The following is a description of a gene set: species: Mus musculus Any process that stimulates, induces or increases the rate of macrophage activation. Mouse Gene Set: GOBP_POSITIVE_REGULATION_OF_MACROPHAGE_ACTIVATION, and this is the list of marker genes: Irgm1, Mmp8, Il4ra, Il10, Kcnn4, Ttbk1, Hspd1, Hamp, Tafa3, Lrrk2, Wnt5a, Jund, Raet1d (retinoic acid early transcript delta), Tlr4, Ctsc, Tlr6, Lgals9, Il33, Kars1, Pla2g4a, Stap1, Cebpa, Il1rl1, Thbs1, Tnip2, Il13 (NCBI Gene Id 16163), Havcr2, Ulbp1, Trem2, Cd1d1, Lbp